The following is a description of a gene set: Pathway Definition from KEGG: (IL2,IL4,IL7,IL9,IL15,IL21,TSLP) -> ((IL2RG+IL2RB+(IL2RA,IL15RA),(IL2RG+(IL4R,IL7R,IL9R,IL21R),(IL7R+CRLF2)) -> (JAK1+JAK3) -> (STAT1,STAT3,STAT5,STAT6) Human Gene Set: KEGG_MEDICUS_REFERENCE_IL2_FAMILY_TO_JAK_STAT_SIGNALING_PATHWAY species: Homo sapiens IL2 family to Jak-STAT signaling pathway. Pathway ID: N01554. Pathway type: Reference. Pathway class: nt06518 JAK-STAT signaling., and this is the list of marker genes: STAT5A, IL7, IL7R, IL2RA, STAT1 (NCBI Gene Id 6772), IL2RG, STAT3, IL4R, TSLP, IL15, CRLF2, IL9R, JAK1, JAK3, IL21R, IL15RA, IL9, IL4, STAT5B, STAT6, IL21, IL2, IL2RB